The following is a description of a gene set: Human Gene Set: REACTOME_PEPTIDE_HORMONE_METABOLISM Peptide hormone metabolism studied in species Homo sapiens, and this is the list of marker genes: EXOC6, CGB3, CMA1, CGA, SPCS3, CPB2, LHB, KLF4, SEC11A, GCG, CTSZ, CRHR2, ACE2, CTSG, CTSD, MYRIP, EXOC1, REN, ENPEP, EXOC4, CPB1, EXOC2, P4HB, INHBA, MBOAT4, EXOC5, RAB27A, GNG13, FSHB (follicle stimulating hormone subunit beta), PCSK1, ISL1, SLC30A8, GRP, PLA2G7, SPCS1 (signal peptidase complex subunit 1), INS, FFAR1, GNAT3, STX1A, UCN, AGT (NCBI Gene Id 183), GNB3, MME, PAX6 (paired box 6), POMC, VAMP2, GH1, ERO1B, SLC30A5, CGB8, CTNNB1, CPE, TSHB, FFAR4, GZMH, MYO5A, DPP4, CLTRN, KIF5A, EXOC8, INHA, GHRL, GIP, ANPEP, SEC11C, INHBB, ACE, IGF1, CPA3, GPR119, CGB5, ATP6AP2, CDX2, KIF5C, ACHE, INHBC, KIF5B, GNB1, CES1 (carboxylesterase 1), TCF7L2, EXOC7, LEP, GATA4, EXOC3, INHBE, BCHE, SPCS2, PCSK2